The following is a description of a gene set: Human Gene Set: GOMF_HISTONE_H3K9ME2_METHYLTRANSFERASE_ACTIVITY studied in species Homo sapiens Catalysis of the reaction: N6,N6-dimethyl-L-lysyl9- + S-adenosyl-L-methionine = H+ + N6,N6,N6-trimethyl-L-lysyl9- + S-adenosyl-L-homocysteine. This reaction is the addition of a single methyl group to the dimethylated lysine residue at position 9 of histone H3, producing histone H3K9me3., and this is the list of marker genes: SETDB1, ASH1L, MECOM, SUV39H1, SETD5, PRDM16, EHMT2, EHMT1